Given this list of marker genes FLNB, TCF4, PTH1R, SMCHD1, MAP3K7, here is a description of the gene set: Human Gene Set: HP_FAILURE_OF_ERUPTION_OF_PERMANENT_TEETH Lack of tooth eruption of the secondary dentition. studied in species Homo sapiens Failure of eruption of permanent teeth